The following is a description of a gene set: In the present study we used Affymetrix oligonucleotide microarrays to produce gene transcription profiles for the major leukocyte types in humans. This comprehensive dataset enabled us to not only establish which genes were expressed in each leukocyte type, but also which genes were expressed in each subset after activation. The used of a comprehensive dataset of gene profiles from all the major human leukocyte subsets enabled a novel and powerful means for identification of genes associated with single leukocyte subsets, or different immune paradigms. from publication Jeffrey KL, Brummer T, Rolph MS, Liu SM, Callejas NA, Grumont RJ, Gillieron C, Mackay F, Grey S, Camps M, Rommel C, Gerondakis SD, Mackay CR (PMID 16474395) Human Gene Set: GSE3982_EOSINOPHIL_VS_MAC_UP studied in species Homo sapiens Genes up-regulated in comparison of eosinophils versus macrophages., and this is the list of marker genes: WIPI1, APOB, NOTCH1, PRDM5, CLBA1, BTNL3, CYP17A1, BBIP1, FAM13B, RIN3, CFP, LPCAT1, MRPL49, PIGH, PCDHGB5, RHOBTB3, PTBP2, SLA, ZNF34, AKAP17A, PDP1, ZNF184, NFX1, TCAP, NOTCH2NLA, DARS1, CLK1, ZDHHC7, PRRG4, PODNL1, MLC1, ITGAL, PRDM12, CDK13, TAX1BP1, UBL5, YY1AP1, GLMN (glomulin, FKBP associated protein), KIF21B, CCR4, NUP133, DLGAP1, MTMR3, AUTS2, UBR5, INPP5A, RPIA, HPCAL4, CDK5R1, RERGL, TOX4, MYT1, KLHL28, TMEM151B, FBXL5, ITGA10, OLIG2, ACACB, MAGOH (mago homolog, exon junction complex subunit), NR4A2, JARID2, LINC01565, CTDSP1, CUTC, TSPAN2, KIF5A (NCBI Gene Id 84710), RUBCN, HEYL (NCBI Gene Id 92408), HHEX, ZNF250, IDH3G, RANBP6, USP15, PLA2G4A, PARP8, POU2F1, RANBP2, ISG15, ISG20, CYFIP2, KBTBD11, SKP2, METTL3, APOA1, TUB, GRIA2, RBM14, ARHGEF40, EPM2AIP1 (NCBI Gene Id 9852), KIT, KLF3, PADI1, LUC7L2, ZSCAN32, HIPK2, CAMKK2 (NCBI Gene Id 121657), MTMR14, FBXO11, EIF1, DNAI7, NXN, ATXN7L3B, PDLIM2, KDM6A, DBT, ZNF117, CTDSP2, ELF2, RSRP1, SYNE1, HNRNPA3P1, DEDD, ANKMY1, SEC14L1 (NCBI Gene Id 6397), ITIH4, PNPLA6, TSPOAP1, RAPGEFL1, ACTB, DDX18 (NCBI Gene Id 8886), SYNE2, CYP2C9, GNAQ, RASSF1, ASNSD1, SDHAF1, ZNF14, MUC2, PIGR, ADIRF, PKNOX2, PPP1R10, TREML2, GLRB, FOXN2, INPP4A, POU3F1, PBXIP1, ALOXE3, PTPN2, MAPKAPK5-AS1, DSC3, PPY2P, RNF39, FOS, ZDHHC13, CDC14A, SULT2A1, PDPR, NOL10, GAB1, HSD17B11, WIF1, SLC44A1 (solute carrier family 44 member 1), PQBP1, MMP25, ARGLU1, PIM2, FPR1, YIF1B, GAD1, ACSBG1, RAB33B, RBM6, VN1R1, S100P, ADD3, ASTE1, LLPH, SENP6, NLRX1, TNFRSF11B, SERPIND1, MUTYH, FUS, RSL24D1 (NCBI Gene Id 51187), IL22, GOLIM4, RABIF, TACC1, POGZ (pogo transposable element derived with ZNF domain), CST8, GPR35, HMGN1, NDST1, ACP3, SLN, RPS10P5, BMS1P20, SCT, LZTR1, PMS2P3, JAK1, TNFRSF1B, REPS2, MOCS3, BTF3P12